Given this list of marker genes Fga, Efemp1, Fbn1, Fgb, Kng1, Kng2, Fgg, Postn, here is a description of the gene set: In this study, we aimed to characterize changes in the extracellular matrix (ECM) composition during insulinoma progression using a quantitative proteomics approach. To do so, we chose a mouse model of insulinoma, a subtype of pancreatic neuroendocrine tumors, characterized by the expression of SV40 large T antigen (Tag) in pancreatic beta-cells driven by the rat insulin promoter (RIP) (RIP1-Tag2 model). This model follows a well-defined timeline of tumor progression: hyperplastic islets appear by 4 weeks of age, angiogenic islets by 7-9 weeks, solid tumors at 10 weeks, and large and invasive adenomas by 12-13 weeks. Using quantitative proteomics based on isobaric peptide labeling (iTRAQ), we profiled the ECM proteomes or matrisomes of various stages: normal pancreatic islets, hyperplastic islets, angiogenic pancreatic islets, and insulinomas. We focused on ECM and ECM-associated proteins along with proteins found in only one of the two replicates but with at least two unique peptides. Applying a moderated F-test, we identified proteins detected in statistically significantly different abundance in tumor samples (hyperplastic, angiogenic islets or isulinomas) as compared to normal pancreatic islets. This gene set lists the matrisome proteins detected in significantly higher abundance during insulinoma progression as compared to normal pancreatic islets. studied in species Mus musculus Matrisome proteins detected in significantly higher abundance in insulinoma (RIP-Tag2 model) as compared to normal islets. from publication Naba A, Clauser KR, Mani DR, Carr SA, Hynes RO (PMID 28071719) Mouse Gene Set: NABA_MATRISOME_INSULINOMA